The following is a description of a gene set: RAF-independent MAPK1/3 activation studied in species Mus musculus Mouse Gene Set: REACTOME_RAF_INDEPENDENT_MAPK1_3_ACTIVATION, and this is the list of marker genes: Il6ra, Dusp7, Jak2, Tyk2, Map2k2, Dusp5, Pea15a, Dusp2, Dusp9, Dusp1, Dusp10, Mapk3, Il6st, Mapk1, Dusp4, Il6, Ptpn11, Dusp8, Cdk1, Map2k1, Dusp6, Dusp16 (NCBI Gene Id 70686)